The following is a description of a gene set: Human Gene Set: GCM_MAX studied in species Homo sapiens Neighborhood of MAX MYC associated factor X in the GCM expression compendium Neighborhood of MAX, and this is the list of marker genes: NOL11, TARDBP, SMAD2, EAPP, USPL1, LSM14A, FAM76B, MYCBP2 (NCBI Gene Id 55685), RBM25, COPS2, ABT1, CSDE1, TCERG1, LEMD3, STAG2, RNF138, MARCHF7, SMG1, CRBN, PRPF40A, MTPN, CLK4, BANF1, CCDC117, MAX, CCAR1, HNRNPR, DCUN1D1, PCF11, MEMO1, LARP7